The following is a description of a gene set: Human Gene Set: GOBP_MELANOSOME_ASSEMBLY species: Homo sapiens The aggregation, arrangement and bonding together of a set of components to form a melanosome, a tissue-specific, membrane-bounded cytoplasmic organelle within which melanin pigments are synthesized and stored., and this is the list of marker genes: HPS5, HPS4 (NCBI Gene Id 89781), AP1B1, HPS3, AP3D1, AP3M1, AP3B1, AP1S2, AP1M1 (NCBI Gene Id 8907), AP3S1, AP1G1, HPS1 (NCBI Gene Id 3257), AP3S2, RAB32, RAB38, AP1S1 (adaptor related protein complex 1 subunit sigma 1), AP1S3, HPS6, ABCB6